The following is a description of a gene set: from publication Ramilo O, Allman W, Chung W, Mejias A, Ardura M, Glaser C, Wittkowski KM, Piqueras B, Banchereau J, Palucka AK, Chaussabel D (PMID 17105821) Human Gene Set: GSE6269_HEALTHY_VS_STAPH_AUREUS_INF_PBMC_UP Genes up-regulated in comparison of peripheral blood mononuclear cells (PBMC) from patients with acute influenza infection versus PBMC from patients with acute S. aureus infection. species: Homo sapiens Each infectious agent represents a unique combination of pathogen-associated molecular patterns that interact with specific pattern-recognition receptors expressed on immune cells. Therefore, we surmised that the blood immune cells of individuals with different infections might bear discriminative transcriptional signatures. Gene expression profiles were obtained for 131 peripheral blood samples from pediatric patients with acute infections caused by influenza A virus, Gram-negative (Escherichia coli) or Gram-positive (Staphylococcus aureus and Streptococcus pneumoniae) bacteria. Thirty-five genes were identified that best discriminate patients with influenza A virus infection from patients with either E coli or S pneumoniae infection. These genes classified with 95% accuracy (35 of 37 samples) an independent set of patients with either influenza A, E coli, or S pneumoniae infection. A different signature discriminated patients with E coli versus S aureus infections with 85% accuracy (34 of 40). Furthermore, distinctive gene expression patterns were observed in patients presenting with respiratory infections of different etiologies. Thus, microarray analyses of patient peripheral blood leukocytes might assist in the differential diagnosis of infectious diseases., and this is the list of marker genes: MRPS18B, LGALS3BP, TIA1, PHACTR2, PARP12, POLR1HASP, ETS1, DCAF15, RBM25, NXF1, MTA1, LNPEP, BCL11A, STAT1, BPTF, OARD1, PLS3, PPAT, NPAT, PML, MED1, SMG7, SOBP, SEMA4F, CXXC1, SPATS2L, U2AF2, CDK12, SHFL, SART3, CHD4, PUM1, ATF7IP, ZKSCAN7, TRMT13, IFI44, SNHG14, MAP7D3, MIR3648-1, MTMR4, USP21, EIF4G1, PRR5, MX1, SUZ12, SPPL2B, OAS1, USO1, CDK13, C2CD3, VPREB3, TGS1, KPNB1, PPID, CRYGS, TRIM38, ISG15, PNISR, TCF4, DCAF17, TMEM255A, BBX, SLC16A7, BRD2, PALM2AKAP2, AIRIM, KLF12, RFC3, KLF2, STOML1, IL2RG, PRIM1, IFITM1, EIF2AK2, DBT, OAS3, SPDL1, SP110, LAMP3, SMC6, RECQL, TRANK1, HACD3, RSRC1, AP3D1, HERC5 (HECT and RLD domain containing E3 ubiquitin protein ligase 5), TRIM14, ATRX, MRPL42, RUSF1, TRIM32, KMT2A, SCAMP1 (NCBI Gene Id 9522), LY6E, OASL, NAA40, UPF2, ISG20, DLAT, DNAJC11, SLC25A12, WASHC4, IFI44L (interferon induced protein 44 like), CISD1, IRF7, MX2, IFI6, TMEM265, CD2AP, USP1, SNAPC3, RAD50, SCAF11 (SR-related CTD associated factor 11), ZWILCH, GPA33, LPIN2, DDX60, GUSBP14 (GUSB pseudogene 14), LARP1, ZNF500, RUBCN, OAS2, PGAP1 (post-GPI attachment to proteins inositol deacylase 1), RHOB, IFITM3, METTL4 (methyltransferase 4, N6-adenosine), ACTR8, MAPRE2, CDC7, NCOA3, SYNCRIP, GPR171, GLG1, SIGLEC1 (NCBI Gene Id 6614, sialic acid binding Ig like lectin 1), SMG1, SMARCA4, ATAD2B, PTPRC, ATP6V0A2, SPOP, JUP (NCBI Gene Id 3728), TRIM5, TRIM22, NFATC2IP, IFITM3P7, TAF1B, PCDH9 (NCBI Gene Id 57123), CD37, ERGIC2, ZBP1, CMTR1, LAX1, THOC2, HERC6, IFI35, ADD3, PUS7, LARP4, TNIK, XAF1, HLA-B (NCBI Gene Id 730410), CEP83, IFI16, PRKD2, OGFOD2, LIMA1, RSAD2, NUDCD3, ADAR, PTPRO, PDHX, SLC25A17